The following is a description of a gene set: Human Gene Set: GOBP_REGULATION_OF_APOPTOTIC_PROCESS_INVOLVED_IN_DEVELOPMENT species: Homo sapiens Any process that modulates the frequency, rate or extent of apoptotic process involved in development., and this is the list of marker genes: PAX2, TNFRSF1A, TGFB2, PML, BMP7, FOXC2, HNF1B, VDR, PAX8, NOTCH1, TNFRSF1B, BAX, MIR19B1, FOXC1, CDKN2A